The following is a description of a gene set: The retinoblastoma (pRB) family proteins regulate the E2F transcription factors; their complexes regulate critical transitions through the cell cycle. The function of these pRB family/E2F complexes, which includes p130/E2F4, in response to genotoxic agents, is not well understood. We investigated the role of E2F4 in the genotoxic stress response. Following radiation treatment, E2F4 colocalized with p130 in the nucleus during a radiation-induced stable G(2)-phase arrest. Arrested cells had significantly decreased expression of Cyclins A2 and B1 and decreased phosphorylation of mitotic protein monoclonal-2 (MPM-2) mitotic proteins. Small interference RNA (siRNA)-mediated knockdown of E2F4 sensitized cells to subsequent irradiation, resulting in enhanced cellular DNA damage and cell death, as determined by caspase activation and decreased clonogenic cell survival. Downstream E2F4 targets potentially involved in the progression from G(2) into M phase were identified by oligonucleotide microarray expression profiling. Chromatin immunoprecipitation localized E2F4 at promoter regions of the Bub3 and Pttg1 mitotic genes following irradiation, which were among the downregulated genes identified by the microarray. These data suggest that in response to radiation, E2F4 becomes active in the nucleus, enforces a stable G(2) arrest by target gene repression, and thus provides increased cell survival ability by minimizing propagation of cells that have irreparable DNA damage. Human Gene Set: CROSBY_E2F4_TARGETS from publication Crosby ME, Jacobberger J, Gupta D, Macklis RM, Almasan A (PMID 17043659) studied in species Mus musculus Putative E2F4 target genes identified as mitotic genes down-regulated in the LNCaP C4-2 cells (prostate cancer) at both 6 and 24 h following irradiation., and this is the list of marker genes: CHEK1, CDC6, BUB1B, CENPE, NDC80, PTTG1